Given this list of marker genes SF3B4, RAI1, TFAP2B, KDM6A (lysine demethylase 6A), GMNN, NONO, POLA1, ERF, IHH, KMT2A, PTH1R, MECOM, FGFR3, NPR3, ERI1, PQBP1, DOCK6, PTDSS1, PUM1, NOG, GNB2, CEP152, MIR17HG, INTU, UBAP2L, EIF2AK3, NFIX, RUNX2, NSDHL, RBBP8, IFT140, IFT57, COL2A1, FGFR1, TRPS1, SLC26A2, KNSTRN, RAB23, PUF60, BMP2, GDF5 (NCBI Gene Id 8200), NEPRO, BMP4, MBD5, FIG4, GJA1, LMNA, FGFR2, BHLHA9, KMT2D, ROR2, MEGF8, NIN, CHSY1, ATP6V1B2, TRPV4, BMPR1B, PHF6, HOXD13, DVL1, SRCAP, MYCN, HOXA13, PIK3CD, WNT5A, PCNT, COL10A1, VAC14, PDE4D, IGF2, TBX5, here is a description of the gene set: Abnormal middle phalanx morphology of the hand studied in species Homo sapiens An anomaly of middle phalanx of finger. Human Gene Set: HP_ABNORMAL_MIDDLE_PHALANX_MORPHOLOGY_OF_THE_HAND